Given this list of marker genes CFHR3, GPATCH2L, STOX2, PROSER1, SULT1E1, YAP1, MAL2, ALKAL1, KCTD5, HSPH1, THUMPD2, TLK1, TRPS1, SLC39A9 (solute carrier family 39 member 9), PLSCR1, MYZAP, KCND2, PER3 (period circadian regulator 3), SLC17A6, ICE2, AASDH, PCDH15, USP9X, WTAP, ZNF275, CLDN8, ZIC4, COL2A1, PLCL1, ZNF624, CNGB3, PPARG, GJC1, ZC3H12C (zinc finger CCCH-type containing 12C), SDE2, PDE3A, RNF2, C7orf33, GUCY1A2, APLN, ADO (NCBI Gene Id 84890), TFPI2, CRAT, LRRC19 (NCBI Gene Id 64922), DUSP12, ZNF490, SLC66A1LP, ERCC6L2, YEATS4, FGF12, CD1C, UPRT, CENPC, PHF6, RORA, SLC16A7, USP1, GLCCI1, CAPRIN1, DDX3X (NCBI Gene Id 730543), GHSR, FAM219A, CNTN4, CEP97, PDE12, MINDY2, KIF23, KIF18A, LARP4, LRCH1, AKAP5, RGS5, KLK7, DLG1, BBX, CAMK2D, WBP4, TCEAL9, FAM83B, UCP3, SLC11A2 (NCBI Gene Id 4891), SLC4A7, GYG1, ABHD5, SRP68, ACTN1, YKT6, KIF20A (kinesin family member 20A), NSG1, KCNH3, MAGI3, USP15, NATD1, CYP26B1, TMX3, FN1, NEGR1, SPRY1, EREG, ZNF780A, NETO1, HDX, SMAD6, PTER, MSANTD1, OTC, LAMA2, HECA (hdc homolog, cell cycle regulator), ZFR, CREB1, HIF1A, SEPTIN2, MCMBP, SCAI, CAMSAP2, CITED2, CDCA3 (cell division cycle associated 3), CYP4F3, ABHD3, RPA1, ANKRD50, UNC80, NFAT5, FAM91A1, CXCL5, TMEM182, TFG, SLC14A1, ACYP2, SATB2, SLC7A3, LSM3, TRDN, SYT10, ZIC1, EPM2AIP1, TOB1, NR4A3, PGAP6, PI4K2B, LIN7A, PCDH11X, CPEB2, SAMD3, CUL5, RD3L, GTF2A1 (NCBI Gene Id 50857), A1CF, DTWD2, ZEB2 (zinc finger E-box binding homeobox 2), HSF5, EVI5, MAPKAP1, RPS6KA6, OGFRL1, CLOCK (clock circadian regulator), RABEP1, DENND2A, MLF2, FGFR2, TNFSF12, IL20RA, SLC20A2 (solute carrier family 20 member 2), ATP5MG, ELAPOR2, BORCS7, SGIP1, RCE1, MTF2, SMS, FOXR2, SLC24A1, TNFSF4, CLPX, MTMR7, SCAMP1, RNF14, SEMA3D, C1D, RAB9A, BCAR3 (BCAR3 adaptor protein, NSP family member), S100A2, ECHDC1, YIPF4, ITGBL1, PDZD2, ANAPC7, PTEN (phosphatase and tensin homolog), DDX3Y, FSBP, LRRC4, MIPOL1, KANSL1L, NEDD1, SEC11A, WNT7A, KLHDC1, MEX3C, ABI1, ZDHHC17, BRF2, STXBP6, KLRG1, RNF217, TBX18, USP6NL, TMEM59, CDKN2AIP, FLII, MMD, RTL6, LIN7C, TBL1XR1 (NCBI Gene Id 81612), VPS54, ADGRA2, COL19A1, WDR43, WDR44, STK32A, PCMT1, PCDH10, TCEAL1, SCRT2, IAH1, KLHL24, QRSL1, GLIPR1L2, GDAP2, PLGRKT, PHACTR4 (NCBI Gene Id 65979), ABHD17B, SHCBP1, KPNA1, VPS25, TMTC1, RIMKLB, CPEB3, PTAR1 (NCBI Gene Id 375743), ADGRG1, OSBPL3, ROR1, FUNDC1, BRD7, DPP8, UCHL5, here is a description of the gene set: from publication Chen Y, Wang X (PMID 31504780) Genes predicted to be targets of miRBase v22 microRNA hsa-miR-889-3p in miRDB v6.0 with MirTarget v4 prediction scores > 80 (high confidence targets). species: Homo sapiens Human Gene Set: MIR889_3P